The following is a description of a gene set: Mouse Gene Set: GOCC_CASPASE_COMPLEX species: Mus musculus A protein complex that contains one or more cysteine-type endopeptidases (also called caspases), which give the complex a peptidase activity with specificity for the hydrolysis of aspartyl bonds. These complexes may be involved e.g. in apoptotic or inflammation processes., and this is the list of marker genes: Capn2, Pigt, Casp9, Pigu, Capns2, Capn1, Pigk, Pigs, Gpaa1, Capns1